The following is a description of a gene set: Human Gene Set: HP_APLASIA_HYPOPLASIA_INVOLVING_THE_SINUSES studied in species Homo sapiens Aplasia/Hypoplasia involving the sinuses Absence or underdevelopment of a cranial sinus or sinuses., and this is the list of marker genes: CTSK, TRIM37, ATRX, FLNA, AMER1, SFRP4, AGA, COL11A1, FUCA1, RUNX2, ALX3, SMCHD1, DNAI1, SIX2, NOTCH2, ALX1